Given this list of marker genes OR3A1, IGHM, ZNF14, CELF1, ZNF350, DDX49, DEPDC5, STEAP1B, H2BC12, CBL, POLR2K, MTFR1, OTUD4, KNTC1, IFNGR1, TGFBRAP1, EIF2AK2, DICER1, MAP3K8, ACHE, HMOX1, ARHGAP24, PECAM1, CLMN, SLC7A7, FKTN, CD1C (NCBI Gene Id 911), SNN, DCLK2, FZD5, SPTSSA, C1R, DNASE1L3, AAK1, TCL1A, TCFL5, RCN1, MBOAT7, FGF20, GNG11, ING1, GRK4, WDFY3, FCRL2, SLC6A5, BRWD1, RFXAP, RAB35, TMEM80, DAZAP2, RIN3, GPR18, ZSCAN18, GRIK3, EPHA2, ZBTB18, IL6, UGCG, BCL7A, BCL2L2, RSF1, ZNF136, KPNA5 (NCBI Gene Id 3841), HERC2, EIF4G3, IFNA1, SLA, MAGEF1, RPP25, LEPROTL1, SNX3, DYNC2H1, PCDHGA3, PIEZO2, ZXDC, IGHD, DTX4, N4BP2L1, TULP4, IFI6, GAS2, MEPCE, NUP214, RPH3A, ACBD4, OSBP, ESRRA, MYOZ2, UBXN6, INTS9, CBFA2T2, LPAR2, AFM, H3-3B, ABCB4, ZBTB39, ALOX15B, PSME4, CAMTA2, DUSP5, NFX1, RAB28, IL10RA, NOTCH2, FGL2, TNS3, VNN1, FCGR2B, PLGRKT (NCBI Gene Id 94530), CD84, DNPH1, ZFY, ULK1, HES1, DHX35, YPEL1, EIF5A, SCAF11, SORBS3, GPM6A, VENTX, CSTF2T, H2AC6, TMEM8B, DUSP2, TRIM9, CDK3, ZC3H12A, TMEM254, BBS7, SPATA20, CHRNA1, BIN3, PLOD1, GRWD1, ENAH (ENAH actin regulator), PLEKHA4, ALOX5AP, SLC7A4, CD72, SYK, RRP1, OR10C1, CBLB (Cbl proto-oncogene B), LDAF1, MAK16, CD79B, AGAP2, RSRC1, PLEK, CRYGC, ZNF432, TSC1, GRAP, FABP2, GGA2, MECR, YBX3, RNF141, ABCA12, ABCA7, KMO, BTG2, KIAA0040, CSGALNACT1, TCF4 (NCBI Gene Id 6925), CD1D, ZNF589, PCDH9, LRIG1 (leucine rich repeats and immunoglobulin like domains 1), PPARD, PRMT3, POU3F3, GGA1, JAK2, CREB3L2, EIF2B3, ARL4C, GTF3C2, FCGR2C, BCL7C, TOR1AIP1, DLEU1, PLEKHA2, KMT2A, KCNK12, IL2, KRT3, MRNIP, TP53BP1, COQ8A, IL1RAPL2, BTG1, MGAM, ATF2, PBX3, FIG4, METTL16, RIPPLY3, NIPBL, here is a description of the gene set: from publication Abbas AR, Baldwin D, Ma Y, Ouyang W, Gurney A, Martin F, Fong S, van Lookeren Campagne M, Godowski P, Williams PM, Chan AC, Clark HF (PMID 15789058) Immune cell-specific expression is one indication of the importance of a gene's role in the immune response. In order to identify such patterns, we set out to broadly profile gene expression in a variety of immune cells. species: Homo sapiens Human Gene Set: GSE22886_IGA_VS_IGM_MEMORY_BCELL_DN Genes down-regulated in comparison of memory IgG IgA B cells versus memory IgM B cells.